Given this list of marker genes CPS1, CCN3, OGFRL1, AMOTL1, SSBP2, RICTOR, PDE6D, ID1, SGK3, RAB27B, PLEKHA8 (NCBI Gene Id 84725), APPBP2, LYPLA1, SNX2, YIPF6 (Yip1 domain family member 6), C1QTNF7 (NCBI Gene Id 83848), SLC17A6, SUSD5, HEMGN, HNRNPLL, DGKI, RAMAC, HMCN1, RAPGEF4, PACRGL, INVS, ATP23, AGPAT5, GAREM1, STRIP2, ZBTB43, RBM27, ZNF605, CLASP1, LRP12, PRTG, LURAP1L, UPRT, VSTM4, CLIC5 (chloride intracellular channel 5), GDF6, FAM133A, FBXO22, S1PR1, G0S2, ERF, FBH1, WASF3, RTN1, MMRN1, NRXN1, MAPK9, TMEM255A (NCBI Gene Id 55026), TM4SF4, TMTC1, CSGALNACT2, TAF4, CCDC90B, STRAP (serine/threonine kinase receptor associated protein), POMP, TLCD4-RWDD3, EIF2AK3, PUM1, DACH1, SMC5, MORC3, ACVR1C, SIRT1, ATXN2L, ZBTB20, PPP1R8, FRMD4B, ZBTB41, LNPEP, PAX8, MEX3B, RYR2, GID4, MIGA1, C1orf141, SELENOS, FGF14, NECAB1, PAPOLA, NIN, LRP6, SPAG9, LEKR1 (NCBI Gene Id 389170), CYCS, PLK2, MRPL50, NR1D2, ASCL1, C10orf88, USP46, RELCH (RAB11 binding and LisH domain, coiled-coil and HEAT repeat containing), RASSF10, BRWD1, TBX4, ZNF280C, CALML4, DISC1, USP31 (NCBI Gene Id 57478), RTKN2, FSD1L, COPA, AXIN2 (NCBI Gene Id 8313), POF1B (NCBI Gene Id 79983), ZNF254, SPACA1, RASSF6, STRN, MTBP, NR4A2, TMOD1, LRRC8D, SLFN14 (NCBI Gene Id 651723), IL6ST, LRIG3 (leucine rich repeats and immunoglobulin like domains 3), C1QTNF9B, EHBP1, KCNJ8, ARHGAP11A, SLC30A5, LRRTM2, TNPO1, AP1AR, MSTN, PCDHGB7, ZMYND11, ZDHHC21, RORA, C8orf44-SGK3 (NCBI Gene Id 100533105), OGG1, CCNYL1, FAM136A, CPSF6, FMR1, EPB41L5, KLF12, FUT9, STXBP5, PLAUR, TBC1D15, C1QTNF9, CCER1, PIGN, FANCA, MEI4, PLCB1, TUSC1, XPO4 (NCBI Gene Id 64328), RCAN2 (regulator of calcineurin 2), MPP2 (NCBI Gene Id 4355), SHC1, SLC5A12, ITGAV, PTER, ZNF211, CNTD1, XPR1, CRACD, TUBGCP5, WASF1, C1QTNF3, FBXO32, here is a description of the gene set: Genes predicted to be targets of miRBase v22 microRNA hsa-miR-2054 in miRDB v6.0 with MirTarget v4 prediction scores > 80 (high confidence targets). from publication Chen Y, Wang X (PMID 31504780) Human Gene Set: MIR2054 studied in species Homo sapiens